The following is a description of a gene set: Genes containing one or more binding sites for (Zfp42) in their promoter regions (TSS -1000,+100 bp) as identified by GTRD version 20.06 ChIP-seq harmonization. from publication Yevshin I, Sharipov R, Kolmykov S, Kondrakhin Y, Kolpakov F (PMID 30445619) Mouse Gene Set: ZFP42_TARGET_GENES studied in species Mus musculus, and this is the list of marker genes: mt-Ty, mt-Tn, mt-Td, mt-Tc, mt-Co1, mt-Ta